Given this list of marker genes Tmem248, Lypd1, Arl5b, Tfrc, Rimbp2, Chd9, Bend3, Ldb3, Tmem164, Sipa1l1, Tnpo1, here is a description of the gene set: Mouse Gene Set: XIE_TRASTUZUMAB_CARDIOTOXICITY_MMU_MIR_200A_3P_GENES from publication Xie S, Zhou N, Su N, Xiao Z, Wei S, Yang Y, Liu J, Li W, Zhang B (PMID 38577019) species: Mus musculus Abstract: Trastuzumab-induced cardiotoxicity (TIC) is a common and serious disease with abnormal cardiac function. Accumulating evidence has indicated certain non-coding RNAs (ncRNAs), functioning as competing endogenous RNAs (ceRNAs), impacting the progression of cardiovascular diseases. Nonetheless, the specific involvement of ncRNA-mediated ceRNA regulatory mechanisms in TIC remains elusive. The present research aims to comprehensively investigate changes in the expressions of all ncRNA using whole-transcriptome RNA sequencing. The sequencing analysis unveiled significant dysregulation, identifying a total of 43 circular RNAs (circRNAs), 270 long noncoding RNAs (lncRNAs), 12 microRNAs (miRNAs), and 4131 mRNAs in trastuzumab-treated mouse hearts. Subsequently, circRNA-based ceRNA networks consisting of 82 nodes and 91 edges, as well as lncRNA-based ceRNA networks comprising 111 nodes and 112 edges, were constructed. Using the CytoNCA plugin, pivotal genes - miR-31-5p and miR-644-5p - were identified within these networks, exhibiting potential relevance in TIC treatment. Additionally, KEGG and GO analyses were conducted to explore the functional pathways associated with the genes within the ceRNA networks. The outcomes of the predicted ceRNAs and bioinformatics analyses elucidated the plausible involvement of ncRNAs in TIC pathogenesis. This insight contributes to a better understanding of underlying mechanisms and aids in identifying promising targets for effective prevention and treatment strategies.